The following is a description of a gene set: studied in species Homo sapiens Neighborhood of MBD4 Neighborhood of MBD4 methyl-CpG binding domain protein 4 in the GNF2 expression compendium Human Gene Set: GNF2_MBD4, and this is the list of marker genes: PAPOLA, PFDN5, PTMA, RPS8, CDV3, ING3, DDX5, NSA2, FAU, MBD4, UBA52, RPL34, RPL22, JUND, WASHC4, UXT, SNX2, NACA, ARMH3, RPS23, SCAF11, RSRC2, INTS8, RPL35A, RPS29